Given this list of marker genes Stambpl1, Lars1, Ubr1, Pdx1, Mtor (NCBI Gene Id 80612), Klhl22, Ep300, Rps6kb1, Sesn1, Rragd, Ubr2, Hnf1a, Sesn2, Rptor, Sesn3, Pik3ca, here is a description of the gene set: species: Mus musculus Any process that results in a change in state or activity of a cell or an organism (in terms of movement, secretion, enzyme production, gene expression, etc.) as a result of a L-leucine stimulus. Mouse Gene Set: GOBP_RESPONSE_TO_L_LEUCINE